Given this list of marker genes MCM6, LCT, MTOR, PGM3, SATB1, here is a description of the gene set: Lactose intolerance An inability to digest lactose. species: Homo sapiens Human Gene Set: HP_LACTOSE_INTOLERANCE